The following is a description of a gene set: The multiplication or reproduction of epithelial cells, resulting in the expansion of a cell population that contributes to the shaping of the lung. species: Homo sapiens Human Gene Set: GOBP_EPITHELIAL_CELL_PROLIFERATION_INVOLVED_IN_LUNG_MORPHOGENESIS, and this is the list of marker genes: CDC42, BMP4, FGFR2 (NCBI Gene Id 2263), MAP2K1, MAP2K2, HMGA2, WNT2, SRSF6, FGF7, FOXP2, SOX9, NFIB